The following is a description of a gene set: species: Homo sapiens Human Gene Set: AAGCACA_MIR218 Genes having at least one occurence of the motif AAGCACA in their 3' untranslated region. The motif represents putative target (that is, seed match) of human mature miRNA hsa-miR-218 (v7.1 miRBase)., and this is the list of marker genes: DAAM1, PCDHA4, TMEM178A, PPP1CB, RNF38, PCDHA2, HLF, PCDHA11, INHBB, SLC6A1, KHDRBS1, GNAI2, DBNDD2, ARPP19, PDGFRA, ATXN2, PTP4A1, NFIX, RPS6KA2, NACC1, SLTM, CSDE1 (cold shock domain containing E1), SPAG9, FBXO28 (NCBI Gene Id 23219), ATP1B1, NRXN3, TMEM151A, LMO3, RIMS3, GAPVD1, TRIM9, SFMBT1, DCUN1D1, RAB8A, HCN4, WDR1, ZEB2, FAM13A, RAB8B, PCNP, BIRC6, SRP72, WDR48, NHSL3, KDM2A, CLK3, FOXN3, ZMIZ2, ATXN1, HCFC1, C6orf62, PUM2, GPAM (glycerol-3-phosphate acyltransferase, mitochondrial), HOXD10, EDEM1, PPME1, RAP1GAP, DNAJC13, PPP2R2C, KCTD9, PCDHA12, RCBTB1, HOXB3, C3orf70 (chromosome 3 open reading frame 70), BMI1, B3GAT1, RNF19B, PARP12, ELMO1, TBC1D8B, SSR1, SHC4, HOXA10, FHOD3, PPARGC1A, PDE12, DPY19L3, MAGI2, EPB41L1, RARA, PRMT3, GABRB3, SERP1, RPS6KA3, WIPF2, ZNF654, PCDHA5, MSL2, ARGLU1 (arginine and glutamate rich 1), CSMD3, GAB2, KCNA3, PHF6, TMEM25, FAM3C, PPP2R2A, EIF5A2, INTS11, DCUN1D4, DBN1, MBD6, CELF6, FRMPD4, ITM2C, L3MBTL3, RTN4, FANCI, KANSL1 (KAT8 regulatory NSL complex subunit 1), YEATS4, EID3, TCF20, IKZF1, HECTD2 (HECT domain E3 ubiquitin protein ligase 2), BCL9, DUSP5 (NCBI Gene Id 1847), KCNIP3, ELFN2, UQCR10, UBQLN2, KCTD16, SCRT2, CPNE8, SV2A, MBNL2, MAFG, CCDC6, CHM, PURB (purine rich element binding protein B), TOB1, HS3ST3B1, SOCS7, ZBTB41, HCN3, BPNT2, ADGRL1, WNT2B, HNRNPC, SENP1, PIK3R1, SLC23A2, LMNB1, ACTN1, SOX11, SPRED2, SEMA6A, MED12L, ZFYVE26, PRKAR2B, CILK1, BAHD1, GRIA2, ERC2, SMC1A, MARCKS, MDGA1, LCORL, DIRAS2, SLC1A2, SOST, ROPN1, JDP2, GPR85, NCAN, KIT, HS3ST2, DKK2, RABEP1, PCGF2, CA2, PLPPR4, PCDHA10, SASH1, PCDHA9 (NCBI Gene Id 9752), ASIC1, HNRNPA1, EFNB2, PCDHA3, HAS3, SNX4, ZDHHC8, MBNL1, ROBO2, ARHGEF12, UBR3, PIEZO2, GSKIP, STXBP1, DCBLD2, GNAI1, MAN2A1, LIFR, CUL3, SLCO5A1, KLF12, RNF220, PPP1CC, RPS6KB1, NAT8L, CTDSPL, GDPD5, PKP4, ADGRB3, DLST, KIF21B (kinesin family member 21B), ZNF609, PCDHA8, ZMAT4, HTR7, LARP4B, NEBL, NDRG4, RAB6A, ST8SIA4, OBI1, SHANK2, PLD5, ZFX, LGR4, TBX15, UBE2Q2, PPP1R26 (NCBI Gene Id 9858), GNB1, PCDHAC2, FCHO2, MAPK8IP3, SYNJ1, DOLPP1, PCDH8, ACSL1, EBF3, NMT2, CCDC88A, TSPAN3, CCDC24, SHTN1, CREBZF, DNAL1, BRINP3, AKIRIN1, PHAF1, HIC2, NPAS2 (NCBI Gene Id 84195), TMEM163, SFRP2, PCDHAC1, MMP24, FRMD4A, CENPB, NPY1R, SOX5, ATAT1, PPP2R5A, SYNGR1, DYNC1LI1 (dynein cytoplasmic 1 light intermediate chain 1), SH3D19, VAT1, USP32 (ubiquitin specific peptidase 32), RICTOR, HAPLN1, GNG3 (G protein subunit gamma 3), ZNF518B, GUCY1A2, EXOC5, RNF139, CACNA1I, ARK2C, ZMIZ1, PLCG1, MKNK1, SOCS3, ROBO1, LASP1, PTPA, GPM6A, ABLIM3, BRPF3, KALRN, CADM2, RIMBP2, GJA1, TTYH3, PTPRA, GRIK3, PRKCE, PCDHA13, PRKG1, RNF103, PUM1, SORCS1, SATB2, SGCZ, RANBP10, ZFP91, CASKIN1, NEURL4, GRIK2, SLC39A1, HOXA1, ZDHHC23, GALNT13, PAX2, RET, INTS6, POLD3 (DNA polymerase delta 3, accessory subunit), MECP2, SIAH2, FBN2, PHETA1 (NCBI Gene Id 144717), NUP50 (nucleoporin 50), ZNF236, HIVEP2, ZNF212, NAV3, JADE2, CHST8, RIMS4, PI4K2A, TRIM35, KLF3, ST18, FZD4 (frizzled class receptor 4), YWHAB, SGCD, ELOVL5, DBNDD1, BCL11B, DLG2, PCDHA6, SPRED1, LRRC7, SACS, EPHA8, TAC1, PRLR, PBX2, NUMB (NCBI Gene Id 94910), SYT13, RNF41, TRHDE, SIK2, THTPA, SLC12A2 (NCBI Gene Id 6558), RTN3, COL1A1, KMT2A, RAB6C, FREM1, TACC1, PCDHA1, GRM1, OXSR1, SHISA6, JADE3, STAM2, TMX1, ANO4, SP1, LPCAT1, OLFM3, FBXO8, SOCS6, GALNT3, MED17, ARID4B, FLRT3, HIVEP1, GOLGA7, SLC24A4, PCDHA7, PEX5L, SRGAP2 (NCBI Gene Id 440748), RUNX2, ARHGAP5, ADIPOR2, UBE2H, TSC22D3, MVB12B, MOSPD1, SEC14L1, MDGA2, GLCE (NCBI Gene Id 90998), NR3C1, HMOX1, SCAMP5, ARL5B, RPS29, ZBTB11, SDC2, GNAO1, SPECC1L, LHFPL6 (LHFPL tetraspan subfamily member 6), MITF (NCBI Gene Id 7487), ANKRD13B, NRXN1, MINAR1, SERTAD2, HNRNPA1L2, RELN, PPP4R3B, SEC61A1